The following is a description of a gene set: Genes up-regulated in DU-145 cells (prostate cancer) in the absence and presence of a dominant negative form of AKT1 upon exposure to HGF for 48 h. studied in species Homo sapiens Human Gene Set: XU_HGF_SIGNALING_NOT_VIA_AKT1_48HR_UP from publication Xu J, Gao M, Fan S, Meng Q, Goldberg ID, Abounader R, Ressom H, Laterra JJ, Rosen EM (PMID 17099727) The cytokine scatter factor (SF) (hepatocyte growth factor) transduces various biologic actions, including cell motility, invasion, angiogenesis and apoptosis inhibition. The latter is relevant to understanding the role of SF in promoting tumor cell survival in different contexts, for example, detachment from basement membrane, growth in metastatic sites and responses to chemo- and radiotherapy. Previously, we showed that SF protects cells against apoptosis owing to DNA damage, by a mechanism involving phosphoinositol-3-kinase/c-Akt signaling. Here, we used DNA microarray assays to identify c-Akt-regulated genes that might contribute to cell protection. DU-145 human prostate cancer cells were transfected+/-a dominant-negative mutant Akt, treated+/-SF and analysed for gene expression using Affymetrix arrays. These studies identified SF-regulated genes for which induction was c-Akt-dependent vs -independent. Selected microarray findings were confirmed by semiquantitative and quantitative reverse transcription-polymerase chain reaction. We tested the contribution of four SF-inducible/c-Akt-dependent genes (AMPD3, EPHB2, MX1 and WNT4) to protection against adriamycin (a DNA topoisomerase IIalpha inhibitor) using RNA interference. Knockdown of each gene except EPHB2 caused a small but significant reduction in the SF cell protection. The lack of effect of EPHB2 knockdown may be due to the fact that DU-145 cells contain a single-mutant EPHB2 allele. A combination of three small interfering RNAs blocked most of the protection by SF in both DU-145 and T47D cells. These findings identify novel c-Akt-regulated genes, some of which contribute to SF-mediated cytoprotection., and this is the list of marker genes: TIMP1, PLAU, CCL20, ECE1, FHL1, CD44, ISG20, ASNS (NCBI Gene Id 440), PHLDA1, HMOX1, UPP1, PCK2, FYN, PPP1R1A, HPCAL1, ARG2, MACF1, MAP4K2, ERCC1, ITPR3, AKAP12, MMP1, CDK17, HMGA1, STC1, SUSD6, CDCP1, GRK5, UAP1, ST6GALNAC4, SLC4A7, RIN2, CARS1, LTB, ITPKA